The following is a description of a gene set: species: Homo sapiens Human Gene Set: GOCC_ATPASE_COMPLEX A protein complex which is capable of ATPase activity., and this is the list of marker genes: BCL11B, MTA3, TMEM199, ACTR6, SMARCA4, ATP6V0E2, BCL11A, BAZ2A, ATP6V1H, BCL7B, MCRS1, PBRM1 (NCBI Gene Id 55292), DPF1, VPS4A, ACTL6A, INO80, BICRA, DDX21, TRRAP, SRCAP, CHRAC1, ATP6V1G1, RUVBL2, SUZ12, INO80D, MTA2, RSF1, ATP6AP2, SS18L1, RUVBL1, SMARCA5, BCL7A, PTPA, NCR1, MBD3, INO80C, CCDC115, ATP6AP1, SS18, RB1, SMARCB1 (NCBI Gene Id 6598), RBBP4, GATAD2B, ANP32E (acidic nuclear phosphoprotein 32 family member E), EP400, RNASEK, ERCC6, ING3, ARID1B, CHD5, ATP6V0D2 (ATPase H+ transporting V0 subunit d2), BRD9, ATP6V1B1 (NCBI Gene Id 525), BRD7, ATP6V0A4, CFDP1, TFPT, SMARCC2, NFRKB, RBBP7, SMARCD3, ACTR5, ATP6V1E1, MYO1C, DPF3, BRD8, GATAD2A, VPS4B, ATP6V1G3, BPTF, ATP6V1D, PHF10, SMARCD1, DEK, ATP6V1F, CDK2AP2, ATP6V0B, CHD4, ATP6V1C1, ACTB, ATP6V0C, YY1, ZNHIT1, ACTL6B, ARID2 (AT-rich interaction domain 2), BCL7C, UCHL5, ATP6V1C2, POLE3, ATP6V0A2, HMGXB4 (NCBI Gene Id 96789), CHD3, ARID1A, TCIRG1, ATP6V1A, CECR2 (NCBI Gene Id 27443), LUZP1, ATP6V0D1, KAT5, SMARCA2, ATP6V0A1, SMARCD2, ATP6V1G2, DPF2, VCP, HDAC2, SMARCC1, SF3B1, MBD2, INO80B, CDK2AP1, SMARCA1, INO80E (INO80 complex subunit E), ATP6V1B2 (ATPase H+ transporting V1 subunit B2), BAZ1A, ACTR8, DMAP1, C17orf49, BICRAL, SPAAR, MYBBP1A (MYB binding protein 1a), BAZ1B, ATP6V0E1, HDAC1, SMARCE1, YY1AP1, MTA1